Given this list of marker genes Gm5703, Gm18701, Gm19136, Hmcn1, Gm8941, Gm10138, Gm18505, Gm28181, Gm19087, Trmt1l, Ptgs2os2, Gm47985, C730036E19Rik, Swt1, Ivns1abp, Gm29398, Ptgs2os, Gm19891, Rnf2, Gm4034, 2310030A07Rik, Mir7682, Edem3, 3110040M04Rik, Niban1, Pla2g4a, Gm17867 (predicted gene, 17867), Gm8947, 2810414N06Rik, Gm18751, Ska2l-ps, Tpr, Gm9687, Pdc, Odr4, Ptgs2, Prg4, Gm22966, Gm4322, Rbm3-ps (RNA binding motif (RNP1, RRM) protein 3), Gm19503, Gm36527, Gm47996, Gm47995, Gm23535, here is a description of the gene set: species: Mus musculus Mouse Gene Set: chr1G1